The following is a description of a gene set: Human Gene Set: HP_EEG_WITH_CONTINUOUS_SLOW_ACTIVITY studied in species Homo sapiens EEG showing diffuse slowing without interruption. EEG with continuous slow activity, and this is the list of marker genes: CHMP2B, TREM2, MAPT, VCP, PSEN1, GRN, TMEM106B, SQSTM1